Given this list of marker genes MTHFD1L, AMDHD1, SHMT2, MTHFD2, UROC1, HAL, MTHFS, FTCD, here is a description of the gene set: studied in species Homo sapiens The chemical reactions and pathways involving formate, also known as methanoate, the anion HCOO- derived from methanoic (formic) acid. Human Gene Set: GOBP_FORMATE_METABOLIC_PROCESS